Given this list of marker genes Pard3, Mgll, Ucn, C9orf72, Mag, Lgi3, Sirt2 (NCBI Gene Id 80489), Dag1 (NCBI Gene Id 13138), Kcnc3, App, Mapt, Bin1, Tiam1 (NCBI Gene Id 28189), Tnfrsf1b, Scn9a, Tubb4a, Kcna4, Map1a, Kcnc1 (potassium voltage gated channel, Shaw-related subfamily, member 1), Dlg4, Sptbn4, Sptbn1, Kcnh1 (potassium voltage-gated channel, subfamily H (eag-related), member 1), Adam22, Chrna7, Iqschfp, Kcnq3, Kif13b, Dlg2, Cnga3, Nrcam, Cdh1, Apbb1 (amyloid beta precursor protein binding family B member 1), Scn1a, Dagla (NCBI Gene Id 269060), Crhbp, Mbp, Kcna2, Dlg1, Clcn2, Kcnj11, Sptan1, Slc1a2, Cntnap1, Adora2a, Thy1, Scn8a, Scn2b (sodium channel, voltage-gated, type II, beta), Cck, Cntnap2, Crh, Ucn3, Pnmt, Cd40, Mapk8ip3, Adora1, Kcna1, Map2, Epb41l3, Cldn5, Kcnab2, Spock1, Camk2d, Robo1, Nav1, Ermn, Dnm1, Ank1, Kcnk4 (NCBI Gene Id 16528), Robo2, Lrrc7, Map1b, Crhr2, Cntn2, Myo1d, Trpm7, Kcnc2, Scn2a, Nfasc, Bcan, Kcnq2, Ank3, Gabbr1, Scn1b, Ncmap, Kcnab1, Lgi1, Hapln2, Myoc, Gjc2, Trim46, Kcnk2, Dbh, here is a description of the gene set: The main axonal trunk, as opposed to the collaterals; i.e., excluding collaterals, terminal, spines, or dendrites. Mouse Gene Set: GOCC_MAIN_AXON species: Mus musculus